The following is a description of a gene set: species: Homo sapiens Human Gene Set: GOBP_NEUTRAL_LIPID_CATABOLIC_PROCESS The chemical reactions and pathways resulting in the breakdown of neutral lipids, lipids only soluble in solvents of very low polarity., and this is the list of marker genes: PNLIPRP1, LYPLA2, ABHD2, GPLD1, PNLIPRP2, PNPLA1 (NCBI Gene Id 285848), LIPC, DGKD, APOC1, APOA4, PNPLA5, GPIHBP1, APOA5, LPL, APOB, ABHD16B, ABHD12B, APOA2, LIPE, FUT1, PIK3CG, PLIN5, AADAC, ABHD16A, CPS1, DAGLB, APOC2, DAGLA, PLB1, PNPLA4, ABHD6, APOC3, DDHD2, ABHD5, FAAH, SORL1, PNLIPRP3, PNPLA3, ABHD12, LIPG, PNPLA2, PNLIP, MGLL